The following is a description of a gene set: Mouse Gene Set: GOBP_NEGATIVE_REGULATION_OF_CYTOPLASMIC_TRANSLATION studied in species Mus musculus Any process that stops, prevents or reduces the frequency, rate or extent of cytoplasmic translation., and this is the list of marker genes: Unk, Rbm24, Cpeb3, Alkbh3, Cpeb1, Cpeb2, Cpeb4, Nmnat2, Fmr1 (fragile X messenger ribonucleoprotein 1), Parp16